Given this list of marker genes CECR7, CD164, MFGE8, NFYC, MDC1, CXCR4, SH3BGRL, TMEM63A, SLC2A3, FADS2, PTPRK, PARP1, ARHGDIB, CELSR1, CDH11, C5orf15, DEPP1, PPT1, ID2, KIFAP3, GNS, PSMB9, ZBED1, CNN3, BMI1, TUBB2B, DEK, WAS, FCGRT, TBCE, SLC30A1, TCF12 (transcription factor 12), CTNNB1, MFAP3, TMEM109, UBXN4, CXCL8, GHRH, GANAB (glucosidase II alpha subunit, NCBI Gene Id 5312), PGRMC1, GABBR1 (gamma-aminobutyric acid type B receptor subunit 1), KDM5C, SH3BP5, PLCG1, EID1, TMEM123, SLC25A36, GPR107, MICB, ZFC3H1, CD46, ATRX, CNOT2, PPIH, DYRK1A, MAGED2, ACVR1B, PPID, BUB3, CCND3, BEX4, MAGED1, ENPP2, TSC22D3, MTMR2, SMC1A, SPG11, FADS1, PRB2, TFAP2C, XPO1, FERMT2, HSF2, here is a description of the gene set: studied in species Homo sapiens Head and neck squamous cell carcinoma (HNSCC) is the sixth most common cancer among men in the developed world. There is a need, for both clinical and scientific reasons, to find markers to identify patients with aggressive disease as early as possible, and to understand the events leading to malignant transformation and susceptibility to metastasis. We report the first large-scale gene expression analysis of a unique HNSCC location, the hypopharynx. Four normal and 34 tumour samples were analysed with 12 600 gene microarrays. Clusters of differentially expressed genes were identified in the chromosomal regions 3q27.3, 17q21.2-q21.31, 7q11.22-q22.1 and 11q13.1-q13.3, which, interestingly, have already been identified by comparative genomic hybridization (CGH) as major regions of gene amplification. We showed that six overexpressed genes (EIF4G1, DVL3, EPHB4, MCM7, BRMS1 and SART1) located in these regions are indeed amplified. We report genes that are highly differentially expressed between 'early' tumours and normal samples. Of these, we validated by quantitative PCR six novel poorly characterized genes. These genes are potential new markers of HNSCC. Comparing patients with relatively nonaggressive and aggressive tumours (without or with clinical evidence of metastasis 3 years after surgery), we identified 164 differentially expressed genes potentially involved in the acquisition of metastatic potential. This study contributes to the understanding of HNSCC, staging patients into prognostic groups and identifying high-risk patients who may benefit from more aggressive treatment. from publication Cromer A, Carles A, Millon R, Ganguli G, Chalmel F, Lemaire F, Young J, Dembélé D, Thibault C, Muller D, Poch O, Abecassis J, Wasylyk B (PMID 14676830) Human Gene Set: CROMER_METASTASIS_UP Metastatic propensity markers of head and neck squamous cell carcinoma (HNSCC): up-regulated in metastatic vs non-metastatic tumors.